Given this list of marker genes ABCA3, SRCAP, ZMPSTE24, JARID2, FOXP1, GJA5, TGFB1, HSPG2, FOXP2, ATN1, HNRNPH1, GJA8, NCKAP1L, FCGR2A, NFIX, PTH1R, SFTPA2, MED12, TCF4, RAB3GAP2, RTEL1, H3-3B (H3.3 histone B), EBF3, TLL1, STN1, NXN, HPGD, SFTPA1 (surfactant protein A1), SFTPC, PARN, WAC, PSMB8, KPTN, DHX30, BMPR1A, KDM6A, RASGRP1, LRBA, H4C5, PKDCC, GJB6, HNRNPH2, MAP1B, RUSC2, DPP9, CREBBP, FAM13A, DSP, DDX59, AHDC1, INTU, MUC5B, KANSL1, CHD1, CD55, CCDC22, CFTR, PAK3, LAMA3, NR2F1, STK11, JAG1, ARID1B, KMT2D (NCBI Gene Id 8085), TERT, EMC1 (ER membrane protein complex subunit 1), ADNP, SLC5A6, LAMB3, EIF2AK4, DEAF1, SLC35C1, BCOR, ATP11A, LZTR1, EZH2, SLCO2A1, MED12L, CAPRIN1, IL21 (interleukin 21), CTCF, ZNF292, NAA10, NLRP3, PRR12, ZNF407, PTEN, TERC, SLC34A2, EP300, RPS23, TBL1XR1, LAMC2, here is a description of the gene set: Abnormal fingertip morphology species: Homo sapiens Human Gene Set: HP_ABNORMAL_FINGERTIP_MORPHOLOGY An abnormal structure of the tip (end) of a finger.